Given this list of marker genes Lpl, Pnliprp1, Apoa2, Pnliprp2, Apom, Lipg, Abcg1 (NCBI Gene Id 11307), Apoc3, Apoa1, Lipc, Pla2g3, Pnlip, Apoa4, Scarb1, Apoe, Pltp, Lcat, Abca5, here is a description of the gene set: Mouse Gene Set: GOBP_HIGH_DENSITY_LIPOPROTEIN_PARTICLE_REMODELING The acquisition, loss or modification of a protein or lipid within a high-density lipoprotein particle, including the hydrolysis of triglyceride by hepatic lipase, with the subsequent loss of free fatty acid, and the transfer of cholesterol esters from LDL to a triglyceride-rich lipoprotein particle by cholesteryl ester transfer protein (CETP), with the simultaneous transfer of triglyceride to LDL. studied in species Mus musculus